The following is a description of a gene set: from publication Dudziak D, Kamphorst AO, Heidkamp GF, Buchholz VR, Trumpfheller C, Yamazaki S, Cheong C, Liu K, Lee HW, Park CG, Steinman RM, Nussenzweig MC (PMID 17204652) species: Homo sapiens Genes down-regulated in cells from Flt3L Melanom injected mice: 33D1+ versus B lymphocytes. Dendritic cells (DCs) process and present self and foreign antigens to induce tolerance or immunity. In vitro models suggest that induction of immunity is controlled by regulating the presentation of antigen, but little is known about how DCs control antigen presentation in vivo. To examine antigen processing and presentation in vivo we specifically targeted antigens to the two major subsets of DCs using chimeric monoclonal antibodies. Unlike CD8+ DCs that express the cell surface protein CD205, CD8- DCs, which are positive for the 33D1 antigen, are specialized for presentation on MHC class II. This difference in antigen processing is intrinsic to the DC subsets and associated with increased expression of proteins associated with MHC processing. Human Gene Set: GSE6259_FLT3L_INDUCED_33D1_POS_DC_VS_BCELL_DN, and this is the list of marker genes: ABCD1, ZNF512, MGRN1, LCP2, CNOT1, SKI, KDM4A, DIAPH1, PPM1H, LRIG1, MORF4L1, CHST11, PBX2, DEK, PRF1, MAPKAPK3, SLC43A3, ST8SIA4, ANAPC13, FOXO3, CENPO, ARHGAP25, CKAP5, TAF7, DNMT1, WAS, STON2, DNTT, TSPAN14, SFMBT2, SGMS1 (NCBI Gene Id 93538), UXS1, FCHSD2, PSENEN, UVSSA, PHKA2, ZNF841, MTSS1, TMEM129, TPP1, PRIMPOL, NFATC2IP, RELCH, TBK1, CEP55, SESN3, DNM2, MAP3K3, TECPR1, NBR1, AFF1, HELZ2, PANK2, CWC25, PIMREG, LAMTOR4, PPP1R12A, RMND5B, METTL27, RACGAP1, EPB41L2, JAK1, SLCO3A1, VPS4B, CDC25B, GDI2, CHMP1A, ZBTB4, ZC3H6, ITPR2 (NCBI Gene Id 3709), ATP6V0D1 (NCBI Gene Id 9114), MUS81, S100PBP, BCL11B (BCL11 transcription factor B), RTF2, NCOA2, TM9SF1, NOD1, WASHC3, LLGL2, TXNDC12, HMOX2, PCYT1B, PDHA1, DUBR, IFT172, FAM156A, ADAM9, SLC6A19, IFT140 (NCBI Gene Id 9742), WASHC1, NAIF1, CCDC82, CPT1A, AP2S1, CENPE, NUMB, FOXJ2, RAD51AP1, PDLIM1, TSC22D4, PIKFYVE, N4BP2, AMN1, EP300, IFNAR1, TMEM63A, PITPNM1, PRR11, TUT4, VPS26C, NRP1, KCTD9, IKZF1 (NCBI Gene Id 55429), GAS2L3, GABARAP, NRDE2, UCKL1, RFX3, MAST3, SERTAD1, SLC25A24 (solute carrier family 25 member 24), FLOT1, LGALS1, NDUFA3, MKI67, RNASEL, NEIL3, TAF1, PDE3B, SLBP, ZBTB8OS, GLB1, ST6GAL1, SUPT20H, DENND6A, EZH1, ADD1, MTA3, WDR76, ATP2B1, FGFR1OP2, USP18, SGK1 (NCBI Gene Id 6446), DOP1B, NBEAL1, NFATC2, RNASE4, BCL10, ARHGAP12 (Rho GTPase activating protein 12), KRBA1, BRWD3, AP3M2, RELL1, GSDMD, ABCA1, PAK6, NIPA1, PCMTD1, TBC1D10B, PSTPIP1, PAGR1, TPD52, PRR13, CHD2, MAML1, STX2, NPAS2, DNAJC5, ABLIM1, DTX3L, TERF1, PHTF1, NCAPD2, RFX5, SYAP1, LGALS9B, RNF114, PXN, GPCPD1, PRKDC, CLN5, MCOLN1, CARD6, H2BC3, ZMAT1, ZRANB3, ZFAND3, ARID4A, UNKL, GBP4, ENSA, WLS, FDPS, C1orf35, ARHGAP1, GPI, CCM2 (CCM2 scaffold protein), PHIP, ATXN7L3